Given this list of marker genes RREB1, GP1BB, ARVCF, TBX1, MYCN, PLD1, UFD1, TMEM260 (transmembrane protein 260), JMJD1C (NCBI Gene Id 9323), HIRA, COMT, SEC24C, here is a description of the gene set: species: Homo sapiens Human Gene Set: HP_TRICUSPID_ATRESIA Tricuspid atresia Failure to develop of the tricuspid valve and thus lack of the normal connection between the right atrium and the right ventricle.